The following is a description of a gene set: Mouse Gene Set: GALIE_TUMOR_STEMNESS_GENES Tumor microenvironment in carcinomas recruits mesenchymal cells with an abnormal proangiogenic and invasive phenotype. It is not clear whether mesenchymal tumor cells (MTCs) derive from the activation of mature fibroblasts or from their stem cell precursors. However, stromal cell activation in tumors resembles in several aspects the mesenchymal rearrangement which normally occurs during reparative processes such as wound healing. Mesenchymal stem cells (MSCs) play a crucial role in developmental and reparative processes and have extraordinary proangiogenic potential, on the basis of which they are thought to show great promise for the treatment of ischemic disorders. Here, we show that MTCs have proangiogenic potential and that they share the transcriptional expression of the best-known proangiogenic factors with MSCs. We also found that MTCs and MSCs have the same molecular signature for stemness-related genes, and that when co-implanted with cancer cells in syngeneic animals MSCs determine early tumor appearance, probably by favoring the angiogenic switch. Our data (1) reveal crucial aspects of the proangiogenic phenotype of MTCs, (2) strongly suggest their stem origin and (3) signal the risk of therapeutic use of MSCs in tumor-promoting conditions. species: Mus musculus from publication Galiè M, Konstantinidou G, Peroni D, Scambi I, Marchini C, Lisi V, Krampera M, Magnani P, Merigo F, Montani M, Boschi F, Marzola P, Orrù R, Farace P, Sbarbati A, Amici A (PMID 17998939) Stemness-related genes changed in A17 carcinomas (MTC, mesenchymal tumor cells) compared with the mesenchymal stem cells (MSC)., and this is the list of marker genes: Krt14, Bmp4, Tgfbr2, Pdgfra, Tnc, Ptch1